The following is a description of a gene set: Genes predicted to be targets of miRBase v22 microRNA hsa-miR-6785-5p in miRDB v6.0 with MirTarget v4 prediction scores > 80 (high confidence targets). Human Gene Set: MIR6785_5P species: Homo sapiens from publication Chen Y, Wang X (PMID 31504780), and this is the list of marker genes: HCFC1, FBXL20, HIPK2, SLC8A1, SOX13, PIGR, PITPNM2, MEX3A, PRICKLE1, CORO2B, SLC22A23, COL11A2, STARD9, SLC2A4, MRTFA, CDC23, PRKCA, ANKRD45, ARNT2, HSPB7, TSPAN18, NECTIN1, DACT1 (dishevelled binding antagonist of beta catenin 1), PTPRB, RBMS2, MYO1C, ZNF544, GGCX, LRP1, AP1S1, PLXNA4, DDX11, TIMP3, PLEKHA5, SORCS1, TMEM63C, HMGXB3, THY1 (NCBI Gene Id 94105), CCDC43, CALN1, TET3, APLNR, CDKN1A, SLC12A4, STIM1, GNAT1, ABO, BCL2L1, CREB3L2, DUSP8, TUBB4A, POLH, SRRM4, NYNRIN, RIMS3, ZNF490, CPQ, GLDN, SLC35F6, SOX12, MVB12B, ATAT1, NACC1, TOMM40, CSF2RB, ABCB8, COL5A3, MYADM, XKR6, KSR2, MLLT6, AGAP1, KRTAP4-11, SAMD10, SYNJ1, PNMA2, HDAC2, DDX18, GRSF1, PACSIN1, HOGA1, MYRF, KIF18B, ARFRP1, S100A5, XYLT1, SH3BP2, COMMD6, NFIC, KCNJ12, NDST1, SLC25A23, PNPLA2, ELAVL1 (ELAV like RNA binding protein 1), ARMC9, F11R, TSKU, ATP8A2 (NCBI Gene Id 51761), EYA3, TNS2, TMEM184B, UTP11, ATXN1, KCNE5, DAB2IP, AR, TPCN1, C9orf78, GANAB (NCBI Gene Id 5312), SV2C, PRR30 (proline rich 30), WBP2, RNF44, KIF19, FIBCD1 (NCBI Gene Id 84929), IFFO2, ATXN2L, SCAMP4, KCNK15, ARHGEF12, MTA2, CNGA2, NRF1, RHOB, ELAVL3, RALGDS, TMEM104, RPL32, AP2A1 (NCBI Gene Id 92649), KCNIP1, SUSD6, TCTN2, FUS, CCDC180, CSMD2, PRG4, MPP2, PBX2, DPF3, APOL6, DRG2, TGFBR3L, NOX1, PHYHIP, MKNK2, VSIR, TMEM276, PFN2, RSPO4, SYT7, HOXC4, TAPBP, SLC4A8, KLRC3 (NCBI Gene Id 3823), C8orf82, ADAM12, IQSEC3, PAPOLG, TRAPPC14, ELK1, RAB5B, ATP2A3, MS4A4A, TBKBP1, C1orf210, PNPLA6, ADAM21, SYP, LENG8, ZNF503, HOXB8, COL6A1, THTPA, SREBF2, MXD3 (NCBI Gene Id 83463), CAMK1, RFT1, CSDE1, NPTXR, ADGRL1, TMEM120B, ABCC12 (NCBI Gene Id 94160), YPEL4, TRIM67, FOXK1, SLC25A45, FGFR1OP2 (NCBI Gene Id 378428), SLC34A2, PACS1, TAF4, ACP3, ARHGAP23, DDAH1, CDC42BPA, MTR, MGAT5B, HK1, DESI1, APOBEC3F, DBNDD2, VSIG10L, MAPT, ZFAND5, SYNGR1, YWHAQ, SETDB1, NF2, POLR1G (NCBI Gene Id 10849), MECP2, CASKIN1 (CASK interacting protein 1), FAIM2, ALPL, PXDC1 (NCBI Gene Id 221749), STX1A, RAB3IL1, JPH1, RAB11B, NGFR, WNT9B, SUPT5H, NAV2, DUSP4, GRIP2, VPS25, PLCXD1, ALPG (NCBI Gene Id 251), SUFU, B9D1, ZNF649, SV2A, TMTC1, PAIP2B, ABHD14B, HOXA1, IRGQ, TFAP2B, NFIX, DTX4, MAFF, FURIN, IL2RG, ZNF609, GFOD2, TMEM252, SCN4B, SCGB2B2, SYN2, CARM1, MAVS, ARHGDIA, PA2G4, VWA5B2, ABCD1, IGSF8, GRK2, NTSR1, ZNF385A, PTGR3, SELENON, POU2AF1, MAP3K9, PTPRJ, AGAP2, LYN (LYN proto-oncogene, Src family tyrosine kinase), RALB, DLK1, BORCS8, PPP1R9B, STX2, RPRD2, SHISA7, NFASC, MYO10, SH3GL1, MPDU1-AS1, YBX2, RAVER1, CTSD, CIT, BICDL1, SMU1, ARPC4-TTLL3, MOB3A, SMPD3, PPARD, DLGAP4, CSDC2, SYT15, ZSCAN30 (NCBI Gene Id 100101467), RAB37, SMARCD1, MNT, PLA2G4E, TMEM201, GAB2 (GRB2 associated binding protein 2), MTF1, ACKR2, TTYH3, ZNF384, RAB30, EEIG1, PURA, KIF5A, SAV1, ALX4, INKA2, RHO, ATF7 (NCBI Gene Id 11016), SLITRK5, POMT2, FLT4, SLC8A2, NUP98, ASIC1, LRRC4B, ENTPD3, GAL3ST3, TFEB, SDK1, DEPDC5, COPS7B, KCND3, ERI3, APCDD1, RPS6KA2, ZBTB4, ENTPD2, SPRY4, ABCG4, IQSEC1, NLGN3 (neuroligin 3), MORC4, KCTD10, SEC22B, RPL15, TAF10, EIF4EBP2, MINK1, TOLLIP, ARHGEF11, SHISA6, KCNQ2 (NCBI Gene Id 3785), ORAI2, C1RL, CYP1A2, GNAO1, PLA2G2A, RPH3AL, CSNK2A1, SENP5, ZNF814, MGRN1, SLC7A1, CASTOR2, CEBPZOS, FAM131C, CCDC69, SDC3, HOOK3, G6PC3, TNK1 (tyrosine kinase non receptor 1), MRPL43, CHST3, BET1L, PKNOX2, SBF1, PIK3C2B, SLC47A1, NOS1, POLR2E, GPRC5A, CDR2L, RRP15, FANCF, ZNF710, TNS1, VPS37C, PDE7A, BSN, ABCB5, RBM24, N4BP1, FBXO10 (NCBI Gene Id 26267), PGAM1, HOXA10, KY, RUSC1, PITPNM3, SPI1, AHDC1, LZTS3, RNF222, MIEF2, MTFMT, MBOAT2, NHERF2, TPBGL, CASP10, RTN3, PNPO, EEF2K, SMG6, ERF, ANKRD52, TAP1, SLC29A3, RNF24, ELFN2 (NCBI Gene Id 729481), CIC, KRT75, NOL9, PRR12, ZCCHC8, FSCN1, RASSF5, PIK3R2, POU2F2, PCBD1, PEX2, DES, GPM6B, DAGLA, PARVG, ARPC2, SLC6A11, MMP19, VAMP2, PRR32, IKZF3, DNM1, FAM120B, MTCL2, KIF21B, PPM1J (protein phosphatase, Mg2+/Mn2+ dependent 1J), RNF38, SERPINA1, RHOC, FAM3D, EFCAB2, SSBP3, PTPRA, CBX6, GSK3A, HYI, ZNF333, CAPZB, RAB35, FOXP4, FNIP1, PPP5D1P, GNL3L, MXRA7, GCDH, NCOR2, PPM1F, OAF, RAP1GAP2, NUTM2G (NUT family member 2G), KCNQ4 (NCBI Gene Id 9132), RBFOX2, KLC2, EDNRA, C20orf96, SYNGAP1, USP37, BAZ2B, NIBAN2, SUSD5, RNMT, BAZ2A, AVPR2, PARP11, PLAGL2, GLP1R, PDLIM2, FAM131B (NCBI Gene Id 9715, family with sequence similarity 131 member B), RAD51B, ULK2, C2CD2L, CYP26B1, UNC5B, SULT1C4, CLIP2, ZNF518B, CSF1, MDM4, WDTC1, BCL9, MYH14 (myosin heavy chain 14), GALNT2, FKBP1B, GRM4, KIAA1549, MDC1, FAT2, APOA5, SARM1, KHSRP, CERCAM, STK35, DAAM2, PTK2, AGPAT1, DNAJB2, ZNF667, NOVA2, PDK2 (NCBI Gene Id 5164), MEF2D, APRG1, RELT (NCBI Gene Id 84957), PSMB2, PCBD2, FBXL18, CNNM1